The following is a description of a gene set: species: Homo sapiens Lower eyelid coloboma A short discontinuity of the margin of the lower eyelid. Human Gene Set: HP_LOWER_EYELID_COLOBOMA, and this is the list of marker genes: EDNRA, TXNL4A, POLR1A, KCTD1, POLR1C, SF3B4, TCOF1, POLR1B, POLR1D, RIPK4